Given this list of marker genes Chrnb2, Slurp2, Tnfsf4, Ngfr, Foxo4 (NCBI Gene Id 54601), Ifih1, Rap1b, Mbd5, Zcchc3, Prmt5, Ntrk3, Tshr (thyroid stimulating hormone receptor), Ggcx, Cyp11b2, Star, Ryr1, Pde4d, Ahcyl1, Marcks (NCBI Gene Id 17118), Rigi, Gstp1, Trpm4, Chrnb1, Erbb2, Ly6e, Epha10, Capn10, Mir154, Stim1, Lonp1, Ldoc1, Cav1, Mup11, Rapgef1, Slc27a4 (NCBI Gene Id 99453), Uchl3, Mstn, Apc, Ephb4, Mtr, Chrne, Ephb1, Pcsk9, Rnf4, Casq2, Slc27a1, Th, Ncoa2, Dmtn, Gria1, Cacna1a, Hdac9, Pik3cg, Insrr, Myo5a, Obp2a, Chrm4, Ehmt2, Diaph1, Ntrk2, Mapk3, Itpr3 (inositol 1,4,5-triphosphate receptor 3), Epha5 (NCBI Gene Id 13839), Comt, Chrna7, Traf2, Dnai1, Eif4ebp2, Bcar3 (NCBI Gene Id 99553), Gucy1b1, Nanog, Chrng, Itgb3, Fdx1, Prkaca, Cflar, Ghsr, Erbb4, Ache, Rangap1, Crhr2, Gcgr, Raf1 (NCBI Gene Id 76876), Max, Fgfr3, Insr, Drd2, Mapk1, Cftr, Nr4a1, Pdk4, Drd3 (dopamine receptor D3), Htt, Dhx9, Ptprv, Grb2, Akt1, Dennd4c, Pdgfrb, Gna15, Mul1, Htr7, Egfr, Atp2b4, Amigo1, Prnp, Ddi2, Mir369, Ly6a, Pklr, Il18, Gabrb3, Gkap1, Gnb5, Pde2a, Trib3, Mgarp, Mtcl2, Chrnd, Crk, Chrm3, Ghrhr, Chrna6, Baiap2, Trpc1, Ddi1, Pde3b (phosphodiesterase 3B, cGMP-inhibited), Htr3a, Fpr-rs4, Wnt10b, Chrm1, Casp7, Mir376a, Pik3r3, Sesn1, Ubr2, Igfbp5, Pip4k2b, Atp1a3, Eprs1, Ltk, Mup3, Rap1a, Mdm2, Ppp1r1b, Zc3hav1, Cacna2d1, Atp2b1, Ubr1, Ripk2, Epg5, Mir409, Chek1, Cyfip1, Vim, Prkcq, Lhcgr, Fut7, Drd5, Aifm1, Nr4a2, Hmgcs2, Umodl1, Recql5, Chrna5, Rbx1, Grb7, Gabrb1, Socs1, Ace, Six1, Ywhag, Enpp1, Prkci, Il1b (interleukin 1 beta), Ly6g, Edn1 (endothelin 1), Jak1, Ralb, P2rx3, Crhbp, Slc1a3, Fgfr1, Xbp1 (NCBI Gene Id 52219), Gpr173, Palm, Mup4, Htr2b, Nfkb1 (nuclear factor of kappa light polypeptide gene enhancer in B cells 1, p105), Rhoq, Gh, Tgfb1, Slc1a2, Gpt, Zfp36l1, Cybb, Grb14, Fbn1, Ins2, Rbm4, Fbp1, Ptprj, Ahsg, Kdm6a, Lpin3, Atrx (NCBI Gene Id 67403), Anxa5, Snx6, Uros, Lgmn, Sorbs1, Pqbp1, Hmga1, Wnt1, Hnrnpk, Hdac8, Ptpre, Cdh1, Mavs, Zfp592, Ly6c2, Inhbb, Scnn1a, Ankrd26, Nkx6-1, Nck1, Slit2 (NCBI Gene Id 338531), Slc7a5, Cpeb1, Nfe2l2, Agap2 (ArfGAP with GTPase domain, ankyrin repeat and PH domain 2), Grin3b, Folr2, Klf16, Glp1r, Mfn2, Chrm2, Blm, Gna11, Zfp106, Mir27a, Fyn, Nucks1, Mir150, Oprm1, Ncstn, Pxn, Rpl23, Slc26a3, Agt, Irs3, Slc30a10, Mzb1, Trpv1, Agtr1b, Camk2a, Cyp11b1, Slc26a6, Fpr-rs7, Bace1, Npm1, Rgs10, Blvrb, Cdk5r1, Nod1, Pou4f2, Appl1, Sox9, Ptgs2, Gclm, Rgs8, Blvra, Gper1, Trim41, Gata1, Lpin2, Axl, Gclc, Fpr2, Pid1, Ly6f, Ly6g6e, Fancb, Mir666, Agtr1a, Hcn3, Ide, Aqp1, Npr2, Ptpn2, Grb10, Casp6, Brca1, Crh, Ppp3ca, Csf1r, Met, Kdr, Larp1, Spidr, Mup5, Pik3r1, Gabrb2, Nlrp3, Ezr, Thbs1, Ly6m, Flna, Leprot, Mir22, Crtc2, Irs2, Cd36, Flt4, Ddr1, Kcnc2, Hcn4, Shoc2, Pax6, Lep, Inpp5k, Dtnbp1, Actb, Inppl1, Gjb2, Afg3l1, Tyro3, Epha4, Lncbate10, Kat2b, Pparg, Pik3ca, Ptpn1, Ror2, Mapk8 (NCBI Gene Id 26419), Htr3b, Stat3 (signal transducer and activator of transcription 3), Nr4a3, Itpr2, Car2, Mir3072, Gm527, Ptpn11, Irs1, Gstm7, Csk, Kit (NCBI Gene Id 16590), Agtr2, Nod2, Epha3, Ly6h, Hsp90b1, Col6a1, Ifnb1, Brip1, Mir539, Ncoa5, Ep300, Flt1, Nr3c2, Map2k1, Map3k7, Lmnb1, Ctsd, P2rx7, Cyp11a1, Cib2, Ncl, Trex1 (NCBI Gene Id 22040), Ddr2, Stat5b, Phip, Ogt, Tek, Ryr2, Bcar1, Kcnq1, Rptor, Stambpl1, Mtor, Prkar1a, Ceacam2, Epha2, Fer, Prkcb, Ret, Sesn3, Mef2c, Eef2k, Mup1, Srebf1, Ptprf, Mir376b, Socs7, Pdgfra, Adipoq, Tmem38a, Mir301, Klf4, Snx5, P2ry12, Ryr3, Cacna1s, Gria2, Ang2, Opa1, Htr4, Cul3, Flt3, Cps1, Pck2, Nscme3l, Akap6, Oaz1, Kcnq3, Chrna4, Bglap3, Chrnb4, Trp53, Rps6kb2, Orai1, Prkcd, Casp3, Parp1, Foxc2, Htr6, Ccl2, Mir496a, Tlr4, Ctnnb1, Agtrap, Nherf1, Syap1, Mapkap1, Mir494, Tsc2, Slc5a5, Jak3, Rgs9, Tnf, Ptger1, Osbpl8, Prkca, Ptpra, Htr2c, Bcl2l2, Itga4, Prkdc, Ahr, Nono, Slc9a1, Tns2, Gck, Jup, Gabra1, Itpr1, Nppc, Scnn1g, Htr1b, Tbc1d4, Tlr2, Crtc1, Ctnna1, Hrh4, Pdxp, Ntrk1, Map3k5, Kank1, Pde12, Reg1, Irs4, Arpc2, Atp5f1a, Egr1, Gna14, Sorbs2, Vwa2, Srsf3, Slc8a3, Vcam1, Pten, Nsmce3, P2rx4, Chrnb3, Fgfr4, Sh2b2, Pkm, Eif4ebp1, Ndel1, Pkd2, Igf1, Ptafr, Ciita, Sos2, Ccna2, Ncoa1, Irf1, Foxo3, Aanat, Afg3l2, Gpd1, Prkd1, Ddx11, Nucb2, Adcy8, Riok3, Cfl1, Drd1, Prkcz, Adipor1, Tie1, Ly6i, Cpeb2, Drd4, Ephb3, Lynx1, Top2b, Folr1, Trarg1, Abcb1a, Pip4k2c, Mir376c, Mat2a (NCBI Gene Id 232087), Igf1r, Oprd1, Prkaa1, Fcgr2b, Ppp1r9b, Rap1gds1, Slc2a4, Erfe, Rapgef2 (NCBI Gene Id 76089), H2az1, Sesn2, Mir377, Golph3, Bglap, Rab10, Pdk2, Kbtbd2, Cyp1b1, Rock2, Ly6g2, Htr1a, Pck1, Adcy5, Mst1r, Ly6g6d, Slc6a4, Socs2, Mir487b, Hdac2, Jak2, Rps6kb1, Musk, Icam1, Rad51, Cav2, Src, Adrb2, Large1, Grk2, Anxa7, Rarres2, Grm5, Lypd1, Appl2, Slc39a14, Kdm1a, Fam114a1, Gnaq, Prmt1, Sorl1, Klf2, Epha6, Daxx, Gdf15, Defb25, Foxo1, Flot1, Gnas, A1bg, Tyk2, Trem2, Mup2, Slc25a33, Sirt6, Gsk3b, Mir654, Stc1, Psen1, Alk, Kcne1, Sik2, Fpr-rs6, Abcc1, Taar1, Chrna1, Serpina12, Ceacam1, Shmt1, Abcc9, Sgk1, Lrp1, Grin2d, Rab8a, Syk, Colec12, Lrrk2, Ptk2, Sting1, Insig2, Rapgef3, Pde3a, Hrh1, Pik3r2, Uso1, Ephb2, Shc1, Mecp2, Ager, Tmem38b, Slc8a1, Akap7, Otop1, Castor2, Ucp2, Hpca, Cdk5, Prkn, Rtf2, Cacnb1, Zbtb7b, Got1, Sp1, Aqp8, Ass1, Bmt2, Pak1, Sirt1, Igf2, Ednra, Akt3, App, Lpin1, Ly6g6g, Scnn1b, Hcn2, Stat6, Epha8, Trim72, Tlr3, Gcg, Ptpn22, Echdc3, Mir24-2, Penk, Fos, Cdk2, Mertk, Gpr21, Glp2r, Rab13, Chmp5, Gfer, Csrp3, Igfbp1, Plcb1, Camp, Ros1 (NCBI Gene Id 19886), Ins1, Lpl, Slc2a8, Gpld1, Ezh2, Htr2a, Akr1c18, Insig1, Mir543, Rragd, Gabrg2, Pip4k2a, Actn2, Hcn1, Stat5a, Esrra, Lars1 (leucyl-tRNA synthetase 1), Pdpk1, Hnrnpd, Ssh1, Sgcb, Chrna3, Gja1, Klhl22, Rock1, Ghr, Mir143, Chrm5, Stxbp4, Bglap2, Adrm1, Gsk3a, Akt2, Akap9, Tlr6, C1qtnf9, Gnai2 (G protein subunit alpha i2), Sos1, Fpr-rs3, Epha7 (Eph receptor A7), Timeless, Hrh3, Castor1, Bcl2l1, Mir23a, Inhba, Nr1h4, Usf1, Mas1, Rela, Rb1, Ffar3, Psca, Socs3, Map1b, Mir382, Cul7, Rac1, Myo1c, Gata5 (NCBI Gene Id 228988), Wdtc1, Gnai3, Gnal, Vps35, Crtc3, Gnao1, Hras, Adcy6, Hsf1, Vamp2, Tlr9, Gpam, Mir544, C2cd5, P2ry6, Rab31, Gnrhr, Arhgef2, Mir1897, Epha1, Cgas, Selenon, Tgm2, Dpep1, Fgfr2, Sfrp1, Chrna2, Ly6c1, Zdhhc7, Mir667, Raet1d, Mir495, Leprotl1, C1qtnf12, Sin3a, Dnm2, Aplp1, Mir208b, Rplp0, Crkl, Hnf1a, Sco1, Fbxw8, Rgs4, Slc1a1 (NCBI Gene Id 319379), Crhr1, Smarcc1, here is a description of the gene set: species: Mus musculus Any process that results in a change in state or activity of a cell (in terms of movement, secretion, enzyme production, gene expression, etc.) as a result of a nitrogen compound stimulus. Mouse Gene Set: GOBP_CELLULAR_RESPONSE_TO_NITROGEN_COMPOUND